The following is a description of a gene set: Human Gene Set: MCGARVEY_SILENCED_BY_METHYLATION_IN_COLON_CANCER Genes silenced in HCT116 cells (colon cancer) by methylation of CpG islands in their promoters. from publication McGarvey KM, Van Neste L, Cope L, Ohm JE, Herman JG, Van Criekinge W, Schuebel KE, Baylin SB (PMID 18632628) Epigenetic gene regulation is a key determinant of heritable gene expression patterns and is critical for normal cellular function. Dysregulation of epigenetic transcriptional control is a fundamental feature of cancer, particularly manifesting as increased promoter DNA methylation with associated aberrant gene silencing, which plays a significant role in tumor progression. We now globally map key chromatin parameters for genes with promoter CpG island DNA hypermethylation in colon cancer cells by combining microarray gene expression analyses with chromatin immunoprecipitation-on-chip technology. We first show that the silent state of such genes universally correlates with a broad distribution of a low but distinct level of the PcG-mediated histone modification, methylation of lysine 27 of histone 3 (H3K27me), and a very low level of the active mark H3K4me2. This chromatin pattern, and particularly H3K4me2 levels, crisply separates DNA-hypermethylated genes from those where histone deacetylation is responsible for transcriptional silencing. Moreover, the chromatin pattern can markedly enhance identification of truly silent and DNA-hypermethylated genes. We additionally find that when DNA-hypermethylated genes are demethylated and reexpressed, they adopt a bivalent chromatin pattern, which is associated with the poised gene expression state of a large group of embryonic stem cell genes and is characterized by an increase in levels of both the H3K27me3 and H3K4me2 marks. Our data have great relevance for the increasing interest in reexpression of DNA-hypermethylated genes for the treatment of cancer. studied in species Homo sapiens, and this is the list of marker genes: TFPI2, RAB32, CTAG2, GATA5, POMC, EFEMP1, HDGFL1, NEURL1, PPP1R14A, EYA4, SOX17, ASCL2, DKK3, INHBB, CHL1, GATA4, JPH3, GNB4, MOV10L1, FOXL2, ICAM1, LEF1, ADAMTS18, GSTM3, ADAMTS15, CABYR, DMRTB1, EPHA4, SFRP5, FOXQ1, SALL4, DDX43, SFRP4, SFRP1, FBLN2, CHFR, UCHL1, HOXD1, JAM3, INHA (inhibin subunit alpha), CBR1, BOLL